The following is a description of a gene set: Any process that activates or increases the frequency, rate or extent of receptor catabolic process. studied in species Mus musculus Mouse Gene Set: GOBP_POSITIVE_REGULATION_OF_RECEPTOR_CATABOLIC_PROCESS, and this is the list of marker genes: Apoe, Laptm5, Itch, Abca2, Hamp2, Ptpn1, Pcsk9, Dtx3l, Hamp, Git1